The following is a description of a gene set: Human Gene Set: GSE35543_IN_VIVO_NTREG_VS_IN_VITRO_ITREG_UP from publication Schmitt EG, Haribhai D, Williams JB, Aggarwal P, Jia S, Charbonnier LM, Yan K, Lorier R, Turner A, Ziegelbauer J, Georgiev P, Simpson P, Salzman NH, Hessner MJ, Broeckel U, Chatila TA, Williams CB (PMID 23125413) species: Homo sapiens Induced Treg (iTreg) cells are essential for tolerance and can be used therapeutically, yet their stability in vivo and mechanisms of suppression are unresolved. Here, we used a treatment model of colitis to examine the role of autologous IL-10 in iTreg cell function. Mice treated with IL-10+/+ iTreg cells in combination with IL-10–/– natural Treg (nTreg) cells survived and gained weight, even though iTreg cells were numerically disadvantaged and comprised just ~20% of all Treg cells in treated mice. Notably, ~85% of the transferred iTreg cells lost Foxp3 expression (ex-iTreg) but retained a portion of the iTreg transcriptome which failed to limit their pathogenic potential. The TCR repertoires of iTreg and ex-iTreg cells exhibited almost no overlap, which indicates that the two populations are clonally unrelated and maintained by different selective pressures. These data demonstrate a potent and critical role for iTreg cell produced IL-10 that can supplant the IL-10 produced by nTreg cells and compensate for the inherent instability of the iTreg population. Genes up-regulated in T reg: in vivo versus in vitro., and this is the list of marker genes: COL8A1, LAD1, LIM2, CYP7B1, CAPNS1, SLC16A10, NAALADL2, KCNMB2 (potassium calcium-activated channel subfamily M regulatory beta subunit 2), OLIG2, CCT3, FOXN1, SEMA4G, PQBP1, SGTB, MDM1, MUC15, CHST1, CLSTN2, ZSWIM4, TMEM207, NWD2, HAPLN3, SYNGR2, CACNB2, AARD, SLC34A1, CBLC, FAM90A13, PLCXD3, NHERF2, MROH9, RSPH4A, CNTN3 (contactin 3), ACSM1, CAPN9, MMGT1, RELN, COL19A1, IL34, IRX5, CIMIP5, NR2F1, SMPD1, ADPRS, EMX2OS, FOXH1, HOXB2, SCD, MACROH2A1, SEPTIN3, KLRG2, ARHGAP28, CRX, NMU, CER1, ZP2, SCN7A, WSB2, PLEKHB1, KCNA5, WDR86, BLTP2, LRRC10B, EMC4, LRRC26, PRKG2, CTSB, GRIA4, MRPS14, POU2F1, H6PD, LCA5L, PRELP, SCRG1, PEMT, DACH1 (dachshund family transcription factor 1), FBXL8, CYP1B1, SLC10A1, SMIM6, CCL21, RHOF, SERTAD4, SEMA3B, BBOF1, RAB27B, C15orf62, IQSEC2, TERF2IP, KEL, DPYS, IL36B, FZD9, CDX4, ZEB2, TICAM1, BBS7, EN1, TCF21, SOHLH1, PARM1, OTOR, ESRP1, PTPRG, OXCT2, HOXD12, PCDH10, TANC2, ZBTB11-AS1, ADIPOQ, MYADML2, ITPRID2, MRFAP1L1, NPY, NXPE4, FOXB1, ELN, COA8, CYP4F22, PCDHB12, TBC1D8, CAPN3, PKHD1, EVI5L, HECTD1 (HECT domain E3 ubiquitin protein ligase 1), KCNK1, PLA2G2A, GATA4, CYP7A1, CD160, PRKAB1, INSM1, ACOT12, FGF5, ADAM2, NR0B1, FNDC11, MYT1L, GGT6, PRDM10-DT, CCL19, ALMS1, WT1, FAM169A, PHYHIPL, DNAJC28, TMT1B, MYT1, ARID3A, PRLR, CLDN14, SMARCA1, PAX6, STAG3, KRTAP20-2, LYNX1, CMTM7, KLHL33, SOX11, MED25, IGLL1, SORCS2, OSBPL7, MPL, PRR32, MEF2C, PCNX2, SRPX, CD300A, TRAM1, CCDC6, ITGB6, MMP16, BMP4, SMCO1, DAPK1, FAM83F, PLCE1, FGF20, PTPN20, CA14, EGR2, ADAMTS1, SMIM31, VPS28, RREB1, ATF5, FIGLA, IMMP2L, KY, KCNK4, KLHL26, GP2, SERPING1, NPVF, PRKAG3, GLI3, AMPD3, TM4SF5